The following is a description of a gene set: species: Mus musculus The process in which a SUMO protein (small ubiquitin-related modifier) is conjugated to a target protein via an isopeptide bond between the carboxy-terminus of SUMO with an epsilon-amino group of a lysine residue of the target protein. Mouse Gene Set: GOBP_PROTEIN_SUMOYLATION, and this is the list of marker genes: Bcl11a, Gnl3, Topors, Zmiz1, Pias1, Gnl3l, Ifih1 (interferon induced with helicase C domain 1), Cbx4, Hdac4, Fscb, Egr1, Trpm4, Stx1a, Hmg20b, Pias4, Sumo3, Ranbp2, Uba2, Capn3 (calpain 3), Tollip, Rnf212, Trim38, Sumo1, Sae1, Senp6, Ctnnb1, Traf7, Egr2, Sumo2, Ahrr, Nsmce2, Rwdd3, Pias3, Park7, Senp1, Eya1, Hmg20a (high mobility group 20A), Zmiz2, Cdkn2a, Pias2, Rela, Rasd2, Mul1, Rangap1, Trim28, Ube2i, Arnt, Zfp451